Given this list of marker genes ZFYVE26, PROM1, PRPH2 (peripherin 2), RLBP1, RHO, RDH5, BEST1, RPGRIP1, PLA2G5, here is a description of the gene set: Human Gene Set: HP_RETINAL_FLECKS species: Homo sapiens Presence of multiple yellowish-white lesions of various size and configuration on the retina not related to vascular lesions. Retinal flecks